The following is a description of a gene set: part of: Post NMDA receptor activation events studied in species Homo sapiens Reactome Pathway: CREB1 phosphorylation through the activation of Adenylate Cyclase Ca2+ influx through activated NMDA receptors in the post synaptic neurons activates adenylate cyclase-mediated signal transduction, leading to the activation of PKA and phosphorylation and activation of CREB1 induced transcription (Masada et al. 2012, Chetkovich et al. 1991, Chetkovich and Sweatt 1993, and this is the list of marker genes: ADCY1, PRKACB, ADCY8, CALM1, PRKAR1A, PRKX, PRKAR1B, PRKAR2B, PRKACG, CREB1, PRKAR2A, PRKACA (protein kinase cAMP-activated catalytic subunit alpha)